Given this list of marker genes ACIN1, PA2G4, GEMIN5, FBL, BOP1, RNGTT, EXOSC8, CSTF1, PPIG, GRSF1, RAE1, DHX16, SLBP, PABPC1, COIL, HNRNPA2B1, here is a description of the gene set: The role of Gemin5 in alternative mRNA splicing, tumor cell motility, and proteomic instability was investigated. Isotope Capture Affinity Tag proteomic analysis was conducted on MDA-MB-435 tumor cells transfected with either a control vector (C-100) or the Nm23-H1 metastasis suppressor (H1-177). Ingenuity pathway analysis revealed that RNA posttranscriptional processing was the most prominent class of differentially expressed proteins. Within this category, overexpression of Acinus1, Poly(a) binding protein, HNRPA2B1, Bop1, and Gemin5 was confirmed in less metastatic H1-177 cells. Overexpression of the latter four proteins was also observed in the lower metastatic antisense Ezrin transfectant of a murine osteosarcoma model system, confirming the general relevance of the trends. Gemin5, a component of the spliceosomal complex, was chosen for further study. Analysis of global mRNA splicing by SpliceArray chips revealed that genes were differentially spliced in C-100 compared with H1-177 cells; transient transfection of gemin5 into C-100 cells restored the splice pattern to that of H1-177 cells. Alternative splicing patterns for the engulfment and cell motility 1 and thrombospondin genes were confirmed by semiquantitative reverse transcription-PCR. Gemin5 overexpression coordinately reduced C-100 cell motility by 50%, and siRNA-mediated reduction of Gemin5 expression increased the motility of H1-177 cells by 2-fold (P < 0.004). The data provide the first demonstration that alterations in the expression of a spliceosome protein can effect both specific splicing events and tumor cell motility. The data also show that changes in mRNA splicing patterns accompany metastatic progression, which may contribute to proteome instability. Human Gene Set: LEE_METASTASIS_AND_RNA_PROCESSING_UP studied in species Homo sapiens Components of RNA post-transcriptional modification machinery up-regulated in MDA-MB-435 cells (breast cancer) whose metastatic potential has been reduced by expression of NME1. from publication Lee JH, Horak CE, Khanna C, Meng Z, Yu LR, Veenstra TD, Steeg PS (PMID 18245461)